The following is a description of a gene set: Human Gene Set: GOBP_NEGATIVE_REGULATION_OF_ADENYLATE_CYCLASE_ACTIVATING_ADRENERGIC_RECEPTOR_SIGNALING_PATHWAY Any process that stops, prevents, or reduces the frequency, rate or extent of an adenylate cyclase-activating adrenergic receptor protein signaling pathway activity. An adrenergic receptor signaling pathway is the series of molecular signals generated as a consequence of an adrenergic receptor binding to one of its physiological ligands. studied in species Homo sapiens, and this is the list of marker genes: CRTC3, PDE4B, ARRDC3, ATP2B4, GNAI2